Given this list of marker genes NOTCH2NLC, GNB2, PDE6H, ACTA2, CRX, KIF21A, IQCB1, CHRNA3, MYH11, PSAP, KIF1B, SH3TC2, ITPR1, MPZ, PEX10, CYSLTR2, CHRM3, RD3, COLQ, PHOX2A, MYL9, GNAQ, MOG, USP45, BAP1, TUBB2B, STIM1, TUBB3, PEX7, DNMBP, PRORP, PMP22, PHYH, ELP1, IFT140, CNGA3, GDF6, LOXL1, TNFSF4, DBH, GNA11, ATP1A3, CTSH, LRAT, TMEM53, IMPDH1, LMO1, SLC1A3, CACNA1A (NCBI Gene Id 773), PRNP, ZNF365, HLA-DRB1, AIMP1, ATF6, CNGB3, PDE6C (NCBI Gene Id 5146), LIN28B, GUCY2D, P2RY11, TUBB4B, KCNJ13, TULP1, COL25A1, SPATA7, HCRT, ORAI1, GNAT2, CHRDL1, DDC, HLA-DQB1, OSTM1, PCYT1A, ERCC6, LCA5, GALC, SIX6, LAMB2, PHOX2B, HHAT, SF3B1, PRPS1, ATP1A2, COL18A1, AIPL1, HACE1, RPGRIP1, CRB1, RAB18, TUBA1A, RDH12, CEP290, RPGR, ALK, NMNAT1, RPE65, MYCN, here is a description of the gene set: Abnormal pupillary function A functional abnormality of the pupil. species: Homo sapiens Human Gene Set: HP_ABNORMAL_PUPILLARY_FUNCTION